The following is a description of a gene set: Human Gene Set: REACTOME_O_LINKED_GLYCOSYLATION species: Homo sapiens O-linked glycosylation, and this is the list of marker genes: GALNT10, ST3GAL3, THBS2, MUC4, SPON2, ADAMTSL5, ST3GAL4, GCNT7, LARGE1, B3GNT6, THSD7B, B3GNT8, POFUT2, B4GALT6, GALNT14, ADAMTS1, MMRN1, ADAMTS6, GCNT4, GALNT7, MUC20, DAG1, ADAMTS7, MUC13, GCNT1, GALNT16, GALNT9, GALNT8, ADAMTS4, SEMA5A, ST3GAL2, ADAMTS2, ADAMTSL4, B3GNT7, B3GNT4, ADAMTS3, MUC6, B3GLCT, ADAMTS14, ADAMTS12, ST6GALNAC2, GALNTL6, ADAMTS18, POMT1, MUC3A, SEMA5B, C1GALT1C1 (C1GALT1 specific chaperone 1), THBS1, MUC17, SSPOP, GALNT4, ST6GAL1, B3GNT5, ADAMTSL1, FUT10, MUCL1, ADAMTS8, MUC5B, ADAMTS10, GALNT1, THSD7A, MUC1, GALNT3, ADAMTS13, CHST4, MMRN2, MUC5AC, ADAMTS15, POMGNT1, SBSPON, GALNT12, GALNT13, A4GNT, B3GALNT2, GALNT18, GALNT17, ST6GALNAC3, MUC7, EMID1, ST6GALNAC4, ADAMTS9, SPON1, B4GALT5 (NCBI Gene Id 9334), GALNT5, GALNT6, B3GNT2, ADAMTS17, ADAMTS5, THSD4, B3GNT3 (UDP-GlcNAc:betaGal beta-1,3-N-acetylglucosaminyltransferase 3), ADAMTSL2, GCNT3, B4GAT1, MUC15, GALNTL5, LARGE2, MUC21, GALNT2, CFP, GALNT11, POMGNT2, MUC12, MUC16, B3GNTL1, C1GALT1, POMT2, ADAMTS20, B3GNT9, POMK, ADAMTSL3, ADAMTS16, FUT11, THSD1, ST3GAL1, ADAMTS19, GALNT15